The following is a description of a gene set: The directed movement of bile acid and bile salts into, out of or within a cell, or between cells, by means of some agent such as a transporter or pore. Human Gene Set: GOBP_BILE_ACID_AND_BILE_SALT_TRANSPORT studied in species Homo sapiens, and this is the list of marker genes: SLCO1A2, ABCC3, SLCO1B3, SLC10A2, SLCO2B1, NR0B2, SLC10A1, SLC51B, ABCC11, ATP8B1, SLC10A5, AKR1C4, CYP7A1, NR1H4, CEACAM1, AKR1C1, SLC10A4, SLC10A6, ABCB11, FGF19, SLC51A, SLCO1B3-SLCO1B7, SLCO1C1, SLCO1B7, ABCD3, SLC10A3, SLCO1B1, SLC27A5, ABCC2, ABCC4